Given this list of marker genes PRIM1 (DNA primase subunit 1), DMAP1, HMCES, H2AX, PRPF19 (NCBI Gene Id 27339), SMARCA5, MCM10, SMARCAD1, TONSL, RADX (RPA1 related single stranded DNA binding protein, X-linked), MCM3, RFC1, CDC5L, TIPIN, CARM1, MMS22L, ERCC5, RAD51B, TIMELESS, CHEK1 (checkpoint kinase 1), UBE2B, RFC5, BCL6, PARP1 (NCBI Gene Id 142), XPA, BCAS2 (NCBI Gene Id 10286), WRN, MRE11, RTF2, PRIMPOL, NBN, RPA3, RECQL5, TREX1, UHRF1, RPA4, RAD51D, RAD51C, BRIP1, RPA2, BLM, PCNA, POLA1, POLA2, POLH, POLD4, XRCC2, CAMSAP3 (calmodulin regulated spectrin associated protein family member 3), DONSON, PLRG1, BAZ1B, EME1, XRCC3, ZRANB3, PRIM2, RFC3, DNMT1, SMARCAL1, RFC4, POLD3, RAD18, TP53BP1, ZMIZ2, TP53, MUS81, HELB, TEX264, ETAA1, EME2, WDHD1, POLD1, POLD2, RFC2, RPA1, here is a description of the gene set: The Y-shaped region of a replicating DNA molecule, resulting from the separation of the DNA strands and in which the synthesis of new strands takes place. Also includes associated protein complexes. Human Gene Set: GOCC_REPLICATION_FORK species: Homo sapiens